The following is a description of a gene set: Human Gene Set: GOMF_METALLOENDOPEPTIDASE_INHIBITOR_ACTIVITY studied in species Homo sapiens Binds to and stops, prevents or reduces the activity of metalloendopeptidases, enzymes that catalyze the hydrolysis of nonterminal peptide bonds in a polypeptide chain and contain a chelated metal ion at their active sites which is essential to their catalytic activity., and this is the list of marker genes: TIMP4, RARRES1, TIMP1, BST2, TIMP2, RECK, COL4A3, LXN, TIMP3, SPOCK1, SPOCK3, NGF, FETUB, SPOCK2